The following is a description of a gene set: Degradation of beta-catenin by the destruction complex studied in species Mus musculus Mouse Gene Set: REACTOME_DEGRADATION_OF_BETA_CATENIN_BY_THE_DESTRUCTION_COMPLEX, and this is the list of marker genes: Psmd6, Psma7, Psmd8, Ppp2r5c, Psma5, Psmb4, Tle3, Psmd11, Psmd1, Axin1, Psma3, Psmd2, Ppp2r1a, Ctnnb1, Cul1, Rps27a, Psmd7, Psmd14, Zranb1, Psmd12, Psmb1 (proteasome (prosome, macropain) subunit, beta type 1), Csnk1a1 (casein kinase 1, alpha 1), Frat2, Psmd13, Psmc2, Ppp2r5b, Ctbp2, Gsk3b, Uba52, Psmc3, Ppp2r5e, Tcf7, Psma6, Psmc1, Skp1, Tle1, Uba52rt (ubiquitin A-52 residue ribosomal protein fusion product 1, retrotransposed), Ppp2r1b, Psma4, Tcf7l2, Psmc5, Ubb, Ppp2r5a, Psmb7, Psmb6, Frat1, Psma1, Psmc6, Amer1, Tle4, Ctbp1, Tle2, Psmd3, Psmb3, Apc, Ppp2cb, Psma2, Rbx1, Ppp2ca, Lef1, Psmb5, Adrm1, Psmc4, Tcf7l1, Psmb2, Ubc, Ppp2r5d